Given this list of marker genes LCN2, HAMP, IFNG, MIR210 (NCBI Gene Id 406992), ISCU, HEPH, here is a description of the gene set: Any process that modulates the frequency, rate or extent of the directed movement of iron ions (Fe) from one side of a membrane to the other by means of some agent such as a transporter or pore. Human Gene Set: GOBP_REGULATION_OF_IRON_ION_TRANSMEMBRANE_TRANSPORT studied in species Homo sapiens